The following is a description of a gene set: Human Gene Set: TSAI_DNAJB4_TARGETS_UP species: Homo sapiens from publication Tsai MF, Wang CC, Chang GC, Chen CY, Chen HY, Cheng CL, Yang YP, Wu CY, Shih FY, Liu CC, Lin HP, Jou YS, Lin SC, Lin CW, Chen WJ, Chan WK, Chen JJ, Yang PC (PMID 16788156) Genes up-regulated in CL1-5 cells (lung cancer) overexpressing DNAJB4 off a plasmid vector. BACKGROUND: We previously identified DnaJ-like heat shock protein (HLJ1) as a gene associated with tumor invasion. Here, we investigated the clinical significance of HLJ1 expression in non-small-cell lung cancer (NSCLC) patients and its role in cancer progression. METHODS: We induced HLJ1 overexpression or knockdown in human lung adenocarcinoma CL1-5 cells and analyzed cell proliferation, anchorage-independent growth, in vivo tumorigenesis, cell motility, invasion, and cell cycle progression. Expression of genes that act downstream of HLJ1 was examined by DNA microarray analysis, pathway analysis, and western blotting. We measured HLJ1 expression in tumors and adjacent normal tissues of 71 NSCLC patients by quantitative reverse transcription-polymerase chain reaction. Associations between HLJ1 expression and disease-free and overall survival were determined using the log-rank test and multivariable Cox proportional hazards regression analysis. Validation was performed in an independent cohort of 56 NSCLC patients. Loss of heterozygosity (LOH) mapping of the HLJ1 locus was analyzed in 48 paired microdissected NSCLC tumors. All statistical tests were two-sided. RESULTS: HLJ1 expression inhibited lung cancer cell proliferation, anchorage-independent growth, tumorigenesis, cell motility, and invasion, and slowed cell cycle progression through a novel STAT1/P21(WAF1) pathway that is independent of P53 and interferon. HLJ1 expression was lower in tumors than in adjacent normal tissue in 55 of 71 patients studied. NSCLC patients with high HLJI expressing tumors had reduced cancer recurrence (hazard ratio = 0.47; 95% confidence interval = 0.23 to 0.93; P =.03) and longer overall survival (HR = 0.38; 95% CI = 0.16 to 0.89; P =.03) than those with low-expressing tumors. Validation in the independent patient cohort confirmed the association between HLJ1 expression and patient outcome. LOH mapping revealed high frequencies (66.7% and 70.8%) of allelic loss and microsatellite instability (87.5% and 95.2%) of the HLJ1 locus at chromosome 1p31.1. CONCLUSIONS: HLJ1 is a novel tumor suppressor in NSCLC, and high HLJ1 expression is associated with reduced cancer recurrence and prolonged survival of NSCLC patients., and this is the list of marker genes: OAS3, TXNIP, ISG15, IFITM1, IRF9, TIMP3, CDKN1A, IFIT3, SERPINB1, IFIT1, STAT1, SESN2, CCNG2